Given this list of marker genes HNRNPD, DHX38, PHB2, OTUB1, DRG1, RPL9, PTBP1 (NCBI Gene Id 63477), PCMT1, SUMO3, ERH, UBN1, RPL18A, COX7A2L, UBC, RNPS1, SNRPB2, ACP1, PSMB3, ATXN10, SEC61B, PUF60, RPL27, SENP3, EIF3K, RPS19, STRAP, PRPF8, RPS7, PTMA, BTF3, ZC3H15, RPL17, DAP3, SUMO2, CLIC1, DDX39B, RPL34, OAZ1, RPS25, SNRNP70, RAF1, YBX1, UBA2, ACTG1, TARDBP, SNRPB, HSP90AA1, COX8A, RPL22, HINT1, NGDN, TRIM28, RPLP2, EIF4A1 (NCBI Gene Id 1973), TUBA1B, RPL7, RHOA, HNRNPA1, MRPL23, UQCRH, YWHAZ, EIF4G2, CALM2, FAM168B, EIF6, EIF3D, NAP1L1, MRPL9, SNRNP200, CDV3, PSMB7, PCBP2, HNRNPM, GANAB, COX4I1, OXA1L, CYC1, CSK, HGS, RPS5, COX7C, IK, DEK, HSP90AB1, RPS12, RPS3A, LSM7, COX6B1, NDUFS3, CNPPD1 (cyclin Pas1/PHO80 domain containing 1), SET, IFT25, COX6A1, COX5B, POLR2A, CNBP, PSMD8, NAP1L4, XPO1, BRD8, RACK1 (receptor for activated C kinase 1), RPL10A, UQCRFS1, RPL19, UBE2L3, RAN, TOP1, RPL31, SNRPE, RPS11, CBX3, TBCB, PPP2CA, LDHA, TIAL1, CHD4, GNB2, RAB8A, H3-3A (NCBI Gene Id 3020), RALY, USP22, SDR39U1, SLC25A6, IDH3B, CANX, SRP14, RPL24, ILF3, KXD1, TUFM, HNRNPAB, ARFGAP2, ATP5F1A, HUWE1, NME2, FUS, NCL, RPL13, SLC25A3, PSMB1, EIF4H, RPS6, HDGF, DAZAP2, HMGN1, AATF, COPS6, BRD2, RPL14, RPL30, PPP2R1A, XRCC6, NUP188, NONO, STARD7, HNRNPK, ATF4, SRSF3, DNAJC8, EEF2 (eukaryotic translation elongation factor 2), PABPC1, PDAP1, RPL5, SRSF9, AP2M1, SART1, RPL21, JTB (NCBI Gene Id 23561), IST1, EIF3H, EIF4A2, YWHAQ, CCT7, EIF3M, UBE2I, RBM3, HNRNPA2B1, BCL7B, CCT2, HNRNPUL1, ANP32B, UBB, TEX261, FOXJ3, UBA1, EIF3I, NACA, GNAS, EEF1D, CTBP1, FBL, PUM1, LYPLA2, ARPC3, FAU, CTDNEP1 (NCBI Gene Id 23399), RPS13, PARK7, KHDRBS1, PTP4A2, SSR2, RPS24 (ribosomal protein S24), BAG6, DDX49, POLE3, ZNF384, ATP6V1F, CFL1, ATP5MC1, HPRT1, PPIA, EEF1G, GPAA1, HSPD1, BANF1, PGK1, NUDT1, ZFPL1, RBMX, RPS27A, LSM14A, U2AF1, ILF2, NPM1, HNRNPC, ANAPC5, CS, KARS1, RPL18, XRCC5, POLR2I, EIF1AX, GDI2, H2AZ2, RPL6, SRSF2, EBP, RPL11, here is a description of the gene set: species: Homo sapiens Neighborhood of UBE2I ubiquitin-conjugating enzyme E2I (UBC9 homolog, yeast) in the MORF expression compendium Neighborhood of UBE2I Human Gene Set: MORF_UBE2I